Given this list of marker genes SREBF1, KPNB1, MBTPS2, PRKACA, STARD4, FGF1, SCAP, ABCG4, AGT, PRKAA1, QKI, SREBF2, MIR182, MAPK1, AGTR1, MIR96, CES1, GNAI1, ABCG1, CYP7A1, APOA1, PAQR3, LDLRAP1, APOE, here is a description of the gene set: Any process that increases the rate, frequency, or extent of cholesterol metabolism, the chemical reactions and pathways involving cholesterol, cholest-5-en-3 beta-ol, the principal sterol of vertebrates and the precursor of many steroids, including bile acids and steroid hormones. Human Gene Set: GOBP_POSITIVE_REGULATION_OF_CHOLESTEROL_METABOLIC_PROCESS species: Homo sapiens